Given this list of marker genes NLRC5, USP18, TRAF6, N4BP1, RPS27A, IKBKG, TP53, UBA52, CASP8, IKBKB, TRAF2, UBC, UBB, NLRX1, CHUK, LRRC14, USP14, IKBIP, here is a description of the gene set: species: Homo sapiens Human Gene Set: REACTOME_REGULATION_OF_NF_KAPPA_B_SIGNALING Regulation of NF-kappa B signaling